Given this list of marker genes MEX3C, AVPI1 (NCBI Gene Id 60370), PMPCA, USP38, GTF3C2, TESK2, IRGQ, NUPR1, ZDHHC18, ACSL3, RHOB, PCBP1, TCF12, HMGCL, ATP6V1C1, FOXN2, SEC14L1, MAFG, TAF4, SMG8, HIVEP3, ACVR1, KLHL25, UBE2Z, JDP2, KCNK13, SPI1, MFSD14A, SRSF6, PRMT9, PLEKHG3, PCNX3, NECAP1 (NECAP endocytosis associated 1), SLC2A1, RELB, GRAMD2B, SETD2, RAB20, ALG9, RBL2, PDLIM7, TNFRSF11A, TNFAIP2, SRFBP1, SEC23B, IER5, GPR65, CPSF7, HS2ST1, TNFRSF1B, PDP1, GIMAP6, FBXO42, ARHGEF7, TRAF3, ARHGEF2, THOC1, SECISBP2, SURF4 (surfeit 4), HCLS1, TMEM37, IFNAR1, SEPHS2 (NCBI Gene Id 339090), SNRNP48, TRAPPC10, PIK3CG, ARMC5, PXN, SERPINB8, ILF3, SGMS1, ZNF217, APBB3, NAF1, TMBIM1, ST3GAL1, RNF2, PTPN23, KPNA1, EYA3, FBXO34, SURF6, PPP1R21, ADORA2B, PCDH7, ADGRE5, CDK9, FASTKD1, HECA, MCOLN2, TJP2, SRXN1, PIGA, EXTL2, FHOD1, WDR81, GIT2 (GIT ArfGAP 2), TOP1, MADD, ZDHHC5, YPEL2, SOWAHC, SKIL, HERPUD1, ARMC7 (armadillo repeat containing 7), ENTPD7, ACSL5, RASSF5, STK40, NFKB2, KDM3B, DCAKD, PAN2, RNF103, OGT, KMT2E, IFNGR2, PRKCD, SIAH1, ARHGAP30, BCL2A1, BIRC3, TBC1D8B, SPECC1, CD33, METTL14, ARL4C, PEX5, GALNT6, NFKB1, FILIP1L (filamin A interacting protein 1 like), STIM2, ADAM17, RCL1, GRAMD1A (GRAM domain containing 1A), TANK, C5AR1, CAPN15, FBRS, ADNP, IRF5, CLPX, WDR5, CLN5, SPRED1, MED23, DLST, SMNDC1, SLC16A10, FAM133B, CACUL1, MKKS, TRIM35, LIG3, CPD, SAMTOR, RILPL2, H6PD, ABCC1, RBMXL1, AP5B1, PEDS1, EIF6 (eukaryotic translation initiation factor 6), FAM20C, RASSF8, ETV3, IFT57, HSPA4 (heat shock protein family A (Hsp70) member 4), TRIT1, PIK3R5, WDR20, KLF7, TSC22D1, LHFPL2, CD300LB, ZBTB21, MED26, SLC7A6OS, B3GNT8, METAP1, SOX4, MTA2, LDLRAP1, SWAP70 (switching B cell complex subunit SWAP70, NCBI Gene Id 23075), RHBDF1, SEC23IP, ACBD3, SUPT20H, CYTH3, B4GALT6, MARK2, JADE2, PLEKHM2, RFFL, SAP30, MTMR14, PLSCR1, PNN, HNRNPLL, here is a description of the gene set: Nlrp10-deficient mice have a profound defect in helper T cell-driven immune responses. T cell priming is impaired due to a defect in the emigration of a dendritic cells from inflamed tissue and antigen transport to draining lymph nodes. DC chemotaxis to CCR7-dependent and independent ligands is intact in the absence of Nlrp10. Therefore to identify novel molecules potentially involved in Nlrp10-dependent DC function we used an unbiased gene array approach on Nlrp10-deficient BMDCs treated with or without LPS. Genes down-regulated in dendritic cells: wildtype versus NLRP10 knockout. Human Gene Set: GSE36009_WT_VS_NLRP10_KO_DC_DN from publication Eisenbarth SC, Williams A, Colegio OR, Meng H, Strowig T, Rongvaux A, Henao-Mejia J, Thaiss CA, Joly S, Gonzalez DG, Xu L, Zenewicz LA, Haberman AM, Elinav E, Kleinstein SH, Sutterwala FS, Flavell RA (PMID 22538615) species: Homo sapiens